Given this list of marker genes ACSL6, YPEL4, RHCE, FLACC1 (flagellum associated containing coiled-coil domains 1), CPOX, STAM, HBG1, SLFN14, E2F2, HBBP1, AHSP, TANGO2, SPTB (spectrin beta, erythrocytic), HMGN1P8, CYP4A22-AS1, TFDP1, GATA1, TSPAN32, ABCC13, GKN2, ENSG00000260592, GCLC, HBA2, BLVRB, HBQ1, GALNT5, ICAM4, GYPA, NFE2, PKLR, RRM2, SPTA1, RGS6, TSPO2, NRIR, MYO18B, SLC2A1, EIF5AP2, STEAP3, TLCD4, YOD1, KLF1, RHAG, ANKLE1, GYPB, ABCB10, HBZP1, MAP2K3, VCF1, ABCB6, C17orf99, TRIM10 (NCBI Gene Id 95309), KEL, UROS, OSBP2, HEMGN, SMIM1, MYL4 (myosin light chain 4), PHOSPHO1 (phosphoethanolamine/phosphocholine phosphatase 1), SLC25A39 (NCBI Gene Id 51629), CAT, RFESD, TMCC2, HBM, HBB, HBZ, EPB42, RHD, XPO7, HMMR, ENSG00000255367, SLC38A5, PLEK2, SNCA, ESPN, CCNE1, CDC27, TLCD4-RWDD3, RNF224, BPGM, OR2W3, LINC01399, GYPE, SLC22A4, SLC14A1, TRAK2, MFSD2B, TDH, EIF2AK1, ALAS2, FAM117A, TFR2, SLC25A37, SEC14L4, UROD, CTSE, PRDX2, TAL1, EPOR, C9orf40, RIPOR3, ANKRD9, LINC02506, HMBS, SLC22A16, H2AC8, CDC25A, ALAD, SLC25A21, UBAC1, XK, HBG2, HBE1, ANK1, SNORD3A, SLC4A1, DCAF12 (DDB1 and CUL4 associated factor 12), TF, GFI1B, PAQR9, ERMAP, STYK1, UBE2O, ENSG00000189316, TFRC, SNX22, TRIM58, H3C11, GLRX5, SCARNA22, BTNL10P, FECH, ART4, IFIT1B, PIP5K1B, KRT1, HBA1, GMPR, here is a description of the gene set: from publication Cao J, O'Day DR, Pliner HA, Kingsley PD, Deng M, Daza RM, Zager MA, Aldinger KA, Blecher-Gonen R, Zhang F, Spielmann M, Palis J, Doherty D, Steemers FJ, Glass IA, Trapnell C, Shendure J (PMID 33184181) The gene expression program underlying the specification of human cell types is of fundamental interest. The study authors generated human cell atlases of gene expression and chromatin accessibility in fetal tissues. For gene expression, the study authors applied three-level combinatorial indexing to >110 samples representing 15 organs, ultimately profiling ~4 million single cells. The study authors leveraged the literature and other atlases to identify and annotate hundreds of cell types and subtypes, both within and across tissues. Our analyses focused on organ-specific specializations of broadly distributed cell types (such as blood, endothelial, and epithelial), sites of fetal erythropoiesis (which notably included the adrenal gland), and integration with mouse developmental atlases (such as conserved specification of blood cells). These data represent a rich resource for the exploration of in vivo human gene expression in diverse tissues and cell types. Human Gene Set: DESCARTES_FETAL_PANCREAS_ERYTHROBLASTS Marker genes curated from the annotated cluster as represented in the Descartes Human Gene Expression During Development database. species: Homo sapiens